Given this list of marker genes SLC12A7 (solute carrier family 12 member 7), TRPV4, AQP1, SLC12A2, LRRC8E, SLC12A4, STK39, SCT, CLCN6, CLNS1A, SLC12A8, E2F4, KCNN4, CLN3, AQP11, SLC12A1, OXSR1, SHANK3, SLC12A3, WNK1, AQP4, ANO6, CCDC51, FSHR, SLC12A6, P2RX7, NPM1, SLC12A9, KCNMA1, GNB3, SLC12A5, SCTR, LRRC8A, ABCB8, GPRC5B, CLCN3, WNK3, here is a description of the gene set: Human Gene Set: GOBP_CELL_VOLUME_HOMEOSTASIS Any process involved in maintaining the steady state of a cell's volume. The cell's volume refers to the three-dimensional space occupied by a cell. species: Homo sapiens